The following is a description of a gene set: Human Gene Set: MIR4283 from publication Chen Y, Wang X (PMID 31504780) Genes predicted to be targets of miRBase v22 microRNA hsa-miR-4283 in miRDB v6.0 with MirTarget v4 prediction scores > 80 (high confidence targets). studied in species Homo sapiens, and this is the list of marker genes: ARHGAP1, SERPINA1 (NCBI Gene Id 5265), FBXL16, FGF13, P2RY8, GNG13, PLA2G2F, LDB3, KIAA1549L, ENTPD6, PLAUR, MECP2 (NCBI Gene Id 8274), KIF21B, POU2F2, COL27A1, CCDC85C, NFX1, KDM2A, SMIM8, DNM1, CACNB1, SPAG7, CASTOR3P, FKBP15, FIGN, PAK4, PRRC2B, ZNF585B, C1orf21, ZNF544, SASH3, STK26, GSTK1, DPM2, TPSAB1, TNFSF14, ADARB2, PMEPA1, TECPR2, CCL16, SLC30A3, TMEM250, RGL2, AEN, GRIK3 (NCBI Gene Id 2899), VPS37C, C14orf132, PEX14, SMIM14, TMEM92, TRPC3, CSK, ST3GAL1, EPHA8, DIPK2B, LINC02908, DGKZ, SYN1, LINC02953, SGPP2, ASIC4 (acid sensing ion channel subunit family member 4), XXYLT1, GIGYF1, LARS2, GPR173, BTBD9, YY1AP1, PFDN1, CLCN7 (chloride voltage-gated channel 7), NCCRP1, USP21, CUX1, ARC, CAMKK2, PLK3, KCNQ1, FURIN, RNF11, TSPOAP1, MYO1D, FAM168A, TPSB2, STK10, WIPF1, ZFR2, APC2, HID1, KIF1B, MTSS2, PDLIM2, TMEM201, TMEM184A, ORAI2, ARFIP2, HPCA, ANGEL1, ST8SIA6, ADORA1, CEMIP, NPM2, MTCL2, RPL28, BCAM, B4GALT2, PRKCA, CLIP2, PPARD, OPRPN, ABI3, SIPA1L1, F5, TSPAN11, ADCY1 (NCBI Gene Id 449484), SKI, FAM53C, IQGAP1, PFKFB4, CCDC157, TUBB4A, KCNIP3, FCHSD1, ASIC1, HTT (huntingtin), PGC, PLAGL2, KIAA0930, RGP1, COL5A3, FAM163A, NR5A1, KCTD2, CDKN1A, SMARCD1, IGF2BP1, TTYH2, TOMM34, PACS2, CNTN2, KRTAP5-7, KCNB1, SIN3B, LNP1, INSYN1, BOK, ERLIN2, ABR, ZNF316, SLC9A5 (NCBI Gene Id 6553), SIRT2, CCDC33, TMED1, PLXNA4, ARHGEF18, GAS7, PLEKHG4B, CLIP3, USP51, SMG7, SYT7, SLC27A4, PAX5, PRSS27, CCDC97, AWAT2, ACAP3 (ArfGAP with coiled-coil, ankyrin repeat and PH domains 3), LRRC20, ILF3, ZBTB22, SMARCB1 (NCBI Gene Id 6598), RIMS4, ZNF398, MEIS2, ABHD4, CSF1, CNGB1, GAL3ST3, ZNF3, ENO2, SLIT3, NUDT16, TAL1, CXCR3, NAA40, RBP2, PRKCE, REXO1, ATOH8, CYB561D1 (cytochrome b561 family member D1), STMN3, NMUR1 (NCBI Gene Id 10316), CDH24, PLXNB2, USP13, FSTL1, ZDHHC3, TMEM125, STK35, PKP1, SPOCK1, FBXL12, TIMP2, MAMLD1, XRCC4, TMEM105, R3HDM4, SPRN, BAP1, TREML4, ZCCHC24, LIN52